Given this list of marker genes Ihh, Cdkn2a, Bmp4 (bone morphogenetic protein 4, NCBI Gene Id 12159), Zc3h8, Shh, Tmem131l, Foxj1, Nfkbid, Zfp608, Erbb2, Clec4g, Rag2, Ptpn2, here is a description of the gene set: Mouse Gene Set: GOBP_NEGATIVE_REGULATION_OF_T_CELL_DIFFERENTIATION_IN_THYMUS Any process that stops, prevents, or reduces the frequency, rate or extent of T cell differentiation in the thymus. studied in species Mus musculus